The following is a description of a gene set: Human Gene Set: HP_DYSGERMINOMA Dysgerminoma The presence of a dysgerminoma, i.e., an undifferentiated germ cell tumor of the ovary. species: Homo sapiens, and this is the list of marker genes: SOX9, OPCML, ERBB2, DHH, CTNNB1, CDH1, MAP3K1, FGFR2, PRKN, PIK3CA, AKT1